Given this list of marker genes FAS, FADD, FASLG, CASP8, CASP10, here is a description of the gene set: studied in species Homo sapiens FasL/ CD95L signaling Human Gene Set: REACTOME_FASL_CD95L_SIGNALING